The following is a description of a gene set: species: Mus musculus Mouse Gene Set: GOBP_RESPONSE_TO_MITOCHONDRIAL_DEPOLARISATION Any process that results in a change in state or activity of a cell (in terms of movement, secretion, enzyme production, gene expression, etc.) in response to the depolarization of one or more mitochondria., and this is the list of marker genes: Becn1, Sqstm1, Ulk1, Atg13, Gps2, Atg14, Ambra1